The following is a description of a gene set: species: Mus musculus This event has been computationally inferred from an event that has been demonstrated in another species.<p>The inference is based on the homology mapping from PANTHER. Briefly, reactions for which all involved PhysicalEntities (in input, output and catalyst) have a mapped orthologue/paralogue (for complexes at least 75% of components must have a mapping) are inferred to the other species. Reactome Pathway: Transport of gamma-carboxylated protein precursors from the endoplasmic reticulum to the Golgi apparatus electronically inferred by orthology from the curated human pathway part of: Gamma-carboxylation, transport, and amino-terminal cleavage of proteins, and this is the list of marker genes: Gas6 (growth arrest specific 6), Proc, F10, Bglap2, F2, F9, F7, Pros1, Proz